The following is a description of a gene set: The ubiquitination by a protein of one or more of its own amino acid residues, or residues on an identical protein. Ubiquitination occurs on the lysine residue by formation of an isopeptide crosslink. studied in species Homo sapiens Human Gene Set: GOBP_PROTEIN_AUTOUBIQUITINATION, and this is the list of marker genes: CBL, ASB4, RAD18, RNF19B (NCBI Gene Id 127544), SASH1, SH3RF2, MARCHF7, STUB1, RNF213, SH3RF3, RAG1, RNF133, ITCH, RNF208, RCHY1, RNF10, RNF186, RNF146, LRRK2, PRKN, RNF183, RNF41, UBE2D3, OBI1, KLHL24, UBE2D2, TRAF6, RNF141 (ring finger protein 141), AMFR (autocrine motility factor receptor), RNF181, RNF220, TRIM21, BRCA1 (BRCA1 DNA repair associated), UBE2T, MDM2, BFAR, UBE3A, MTA1, RNF122, TRIM37, TRIM17, RNFT1 (ring finger protein, transmembrane 1), DDB2 (damage specific DNA binding protein 2), TRIM13, UBE4B, DTX3L, LRSAM1, TRIM11, TRIM68, RNF187 (NCBI Gene Id 149603), RNF115, RNF8, RNF4, TRIM71, TAF1, RNF112, CUL3, TRIM52, UBE2B, SH3RF1, RNF185, ERCC8, UBE3D, RNF13, RBX1, TRAF2, NFX1, TRIM58, WWP2, RNF11, LTN1, MARCHF5, CNOT4, UHRF1, UHRF2